The following is a description of a gene set: Human Gene Set: GAVISH_3CA_METAPROGRAM_ENDOTHELIAL_STRESS studied in species Homo sapiens from publication Gavish A, Tyler M, Greenwald AC, Hoefflin R, Simkin D, Tschernichovsky R, Galili Darnell N, Somech E, Barbolin C, Antman T, Kovarsky D, Barrett T, Gonzalez Castro LN, Halder D, Chanoch-Myers R, Laffy J, Mints M, Wider A, Tal R, Spitzer A, Hara T, Raitses-Gurevich M, Stossel C, Golan T, Tirosh A, Suvà ML, Puram SV, Tirosh I (PMID 37258682) Genes upregulated in subsets of cells of a given type within various tumors In this study, an extensive analysis was conducted to define meta-programs (MPs) capturing intra-tumor heterogeneity across a spectrum of tumor types. The approach utilized non-negative matrix factorization (NMF) to analyze each cell type separately within individual tumor samples. This involved the analysis of malignant cells, macrophages, fibroblasts, endothelial cells, epithelial cells, T-cells, and B-cells. NMF was executed with varying parameter values (K=4, 5, 6, 7, 8, 9), thereby generating 39 programs for each cell type per sample. Each NMF program was summarized by the top genes based on NMF coefficients.\nRobust MPs were then delineated for each cell type using a set of stringent criteria, including recurrence within the same tumor, similarity to programs in other tumors, and non-redundancy within a tumor. Subsequently, these robust NMF programs were clustered (per cell type) based on Jaccard similarity, leading to the identification of MPs associated with each cell type.\nTo enhance the quality of the MPs, a refinement steps were undertaken, involving the removal of MPs suspected of reflecting low-quality data (with an overrepresentation of ribosomal proteins or mitochondrial-encoded genes), single-study inclusion, or similarity to miss-annotated cell types., and this is the list of marker genes: C11orf96 (chromosome 11 open reading frame 96), EGR1, HSPA1A, MCL1, SERTAD1, BAG3, FOSB, IER3, HSPH1, CDKN1A, KDM6B, ARID5A, ZC3HAV1, HSPA1B, BTG2, FOS, DNAJB1, ZFP36, CSRNP1, KLF4, CXCL2, DNAJA1, NFKBIA, PPP1R15A, BRD2, MIDN, HES1, FOSL2, RND1, SOCS3, SLC2A3, ATF3, MAFF (MAF bZIP transcription factor F), CCL2, NR4A1, ADAMTS1, TNFRSF10D, SOD2, JUN, CCNL1 (NCBI Gene Id 57018), NFKBIZ, JUND, IRF1, IER2, HEXIM1, BHLHE40, JUNB, APOLD1, GADD45B, ICAM1